Given this list of marker genes RHOT2, MFN2, RAP1GDS1, MYO19, TRAK2, TRAK1, MFN1 (NCBI Gene Id 55669), here is a description of the gene set: species: Homo sapiens This pathway catalogues guanine nucleotide exchange factors (GEFs) and effectors of RHOT2 (also known as MIRO-2). RHOT2 possesses a high intrinsic GTP-ase activity and does not require a GTPase activator protein (GAP). No GDP dissociation inhibitors (GDIs) have been reported to interact with RHOT2. RHOT2 is a mitochondrial RHO GTPase. Like related RHOT1 (MIRO-1), RHOT2 localizes to the outer mitochondrial membrane. Similar to RHOT1, RHOT2 regulates mitochondrial movement by coupling mitochondria to kinesin and dynein motors that transport them along microtubules. RHOT2 is also localized to peroxisomes and it is involved in peroxisomal dynamics. Reactome Pathway: RHOT2 GTPase cycle part of: Miro GTPase Cycle